Given this list of marker genes RASA1, SEMA4D, CTRC, EPHB4, IL23R, MYD88, TSC2, HLA-B, ACTA1, FSHR, CTLA4, SPINK1, KLRC4, SCARB2, IL12A-AS1, MAP2K1, MTO1, IFIH1, IL6, CALCRL, BCL6, CCBE1, HFE, LACC1, VPS51, BLTP1, STAT3, HLA-DRB1, PIEZO1, TSC1, BCL2, GAA, BAP1 (NCBI Gene Id 8314), BMP2, C4A, SOX18, DNASE1L3, PLVAP, LYST (lysosomal trafficking regulator), PTPN22, FAT4, ACTN4, SEC61A1, SPP1, PRSS1, FAS, MST1 (macrophage stimulating 1), NR1H4, KIF11, IL10, GPR35, TLR4, AGR2, ALG14, MEFV, EIF2AK4, CBL, PRTN3, LZTR1, CYBB, ADAMTS3, BTNL2, CYBC1, HLA-DPB1, DEF6, CFTR, FOXF1, SCN4A, USP18 (ubiquitin specific peptidase 18), FOXC2, CFH, UBAC2, PTPN11, CD46, CCR1, CCND1, IFNGR1 (NCBI Gene Id 3459), RIT1, ZNFX1 (NCBI Gene Id 57169), PRSS2, STAT4, TCF4, SAT1, HELLPAR, IRAK1, CAV1, PRKAG2, CFI, IL12A, TAPT1, HLA-DPA1, MIF, ERAP1, BRAF, ITK, here is a description of the gene set: Pleural effusion species: Homo sapiens Human Gene Set: HP_PLEURAL_EFFUSION The presence of an excessive amount of fluid in the pleural cavity.